Given this list of marker genes YWHAE (tyrosine 3-monooxygenase/tryptophan 5-monooxygenase activation protein epsilon), ABL1, TERF2, TINF2, NBN, MYC, PARP2, E2F1, HNRNPC, IL2, HSP90AA1, TERT, IFNAR2, UBE3A, ZNFX1, HUS1, CDKN1B, TGFB1, NCL, ACD, RAD50, SMG5, MAPK3, NR2F2, WRN, EGFR, CCND1, PINX1, IFNG, RPS6KB1, HDAC1, WT1, HDAC2, TERF2IP, IRF1, SMAD3, TNKS, DKC1, RAD1, EGF, MAPK1 (mitogen-activated protein kinase 1), SMG6, NFKB1, POT1, AKT1, SAP30, SIN3A, FOS, PTGES3, SAP18, TERF1, XRCC6, RBBP4, ATM, ESR1, RAD9A, XRCC5, SP3, SIN3B, BLM, MTOR, MAX, SP1, RBBP7, MXD1, JUN, MRE11, here is a description of the gene set: studied in species Homo sapiens Human Gene Set: PID_TELOMERASE_PATHWAY from publication Schaefer CF, Anthony K, Krupa S, Buchoff J, Day M, Hannay T, Buetow KH (PMID 18832364) Regulation of Telomerase